Given this list of marker genes LYPLA1, FAM8A1, CX3CR1, CD33, ADCY10P1, CARD6, TAPT1, TMEM121B, JUNB, THOC5, ARHGAP9, ROPN1L, LRP10, NFS1, GAA, DSC2, AIM2, ARPC2, GMIP, LIMK2, SRP9, DCTN3, TUBA3D, GALNT3, MAU2, ZBTB38, TOR1AIP1, EIF4E3, LILRB3, KCTD21, S100A8 (S100 calcium binding protein A8), NUDT5, UBA3, PYGL, GCNA, BCR, S1PR4, PKN2, UBR2, GLUD1, INTS3, MAP3K1, PGLS, HYCC2, TAPBP, MPRIP, RFX1, TRAPPC6B, CARHSP1, MED23, GOLM2 (NCBI Gene Id 113201), SCO2, MSRA, HERC1, PRKDC, RELL1, SDC2, FHIP2A, GRAMD1C, RNF149, GPAT3, ZKSCAN4, NT5C3A, TOPBP1, SMAP2, NRBF2, OASL, UBXN2B, METTL4, SNORA28, JAK2, CAMP, MICAL2, EML3, WDTC1, LMBRD1, DCTN4, OTULINL, LBR, ACSL1, CSF3R, FAM117A, ARHGAP19, INPP1, TIMP2, SAMD9, WIPF1, PPP1R12A, CXorf38, MEGF9, PHF20L1 (PHD finger protein 20 like 1), ZNF92, SIRPD, SNX2, RUNX2, TSPO, PRCP, CREB5, ZBP1, ANKRD50, APOBEC3G, ALDH9A1, NLRX1, SCAP, SYNE1, TACC1, FCGR3B, RNF167, SEC11A, LCP1, KLHL2, C21orf91, HIRA, STK17B, PADI2, ATF6, FAM117B, RCAN1, CNN2, LCLAT1, NDC80 (NCBI Gene Id 10403), XKR8, STK38, VPS13C, TMEM272, CST7, NHS (NCBI Gene Id 907), EVI5, TBL1X, NASP, RAMAC, TYROBP, ZC3HAV1, GIMAP2, MSL1, APBB1IP, PRPF18, CYP4F3, MTM1, SNX18, IFIT5, ARRDC1, DHRS12, R3HDM4, KDM3B, OAZ2, ARID4B, ARIH2, CEACAM3, TMEM45B, CNPY3, SNAP23 (synaptosome associated protein 23), SHKBP1, NAIP, TNFAIP8L2, CRLF3, TBC1D14, RASA1, TMEM65, PXN (paxillin), CAB39, NOTCH2, SH3BGRL, PLIN5, RNF44, NFAM1, PHF2, SCPEP1, IDS, SELP, CAMK1D, LGALS9, TMEM50A, CHPT1, ACAP1, RFX2, RNF6, SLC8A1, ITGB2-AS1, PPP2R5C, PLGRKT, PLCB2, RC3H1, KPNA2, RFC2, MSRB2, CRISPLD2, AGPAT1, FYB1, ITGB2, IL6R, CYP4F2, RBMXL1, TOPORS (NCBI Gene Id 641432), CCDC186, CMTM3, PTTG2, here is a description of the gene set: We demonstrated recently that both constitutive and FAS-triggered apoptosis of human neutrophils are profoundly impaired by Francisella tularensis, but how this is achieved is largely unknown. To test the hypothesis that changes in neutrophil gene expression contribute to this phenotype, we used human oligonucleotide microarrays to identify differentially regulated genes in cells infected with F. tularensis strain LVS compared with uninfected controls. In order to examine the effect of F. tularensis on the neutrophil transcriptome, we performed microarray expression analysis on human neutrophils treated with F. tularensis subsp. holarctica live vaccine strain (LVS). Human Gene Set: GSE37416_0H_VS_48H_F_TULARENSIS_LVS_NEUTROPHIL_UP Genes up-regulated in comparison of control polymorphonuclear leukocytes (PMN) at 0 h versus PMN treated with F. tularensis vaccine at 48 h. from publication Schwartz JT, Bandyopadhyay S, Kobayashi SD, McCracken J, Whitney AR, Deleo FR, Allen LA (PMID 22986450) studied in species Homo sapiens